The following is a description of a gene set: species: Homo sapiens Genes predicted to be targets of miRBase v22 microRNA hsa-miR-194-5p in miRDB v6.0 with MirTarget v4 prediction scores > 80 (high confidence targets). Human Gene Set: MIR194_5P from publication Chen Y, Wang X (PMID 31504780), and this is the list of marker genes: BRMS1L, SOX5, KDM5A, RHEB, MID1IP1, CPED1, BTBD7, BCKDHA, DACH1, TCEAL4, CASK, ITPKB, SPRED1, XPNPEP3, WDR37, STEAP2, ZFHX3, TSPAN7, PELO, NMB, NRN1, CLCN5, RPL17-C18orf32, NEMP1, SLK (STE20 like kinase), ACVR2B, ATP2C1, HBEGF, ACBD3, CHORDC1, CHD1, RAI1, CNR1, NIPSNAP3B, CUL4B, YTHDF1, RNF125, QKI, MRS2, KIAA1210, MTMR6, LYN, LPXN, RAB38, LINC02902, TRIM23, IVNS1ABP, HHLA2, MGAT4A, SLC12A6, OR51E2, KRT25, CLEC2A, ARK2N, MINDY2, REV3L, TAOK1, ZNF532, CADM1, GORAB, TTC7B, DYRK1A, ZNF615, CNPY1, SNAP91, MEP1A, HOOK3, SLC25A27, KHDRBS2, ARHGAP21, SLC30A1, TMEM108 (transmembrane protein 108), PAIP2, RSBN1L, CAPS2, PDHB, C21orf91 (NCBI Gene Id 89755), FGA, MTSS1, IGF1R, NWD2, LSAMP, FAM169A, ATP6V1H, PTPN12, GOT2 (NCBI Gene Id 2806), RNGTT, LCOR, PRICKLE2, CDK14, WWP1, TAF4, LURAP1L, SFRP2, GPATCH2L, MAP2, FOXE1, DSTYK (NCBI Gene Id 353293), EMCN, STAU2, CHD4, KCTD17, EPC2, SLC12A2 (solute carrier family 12 member 2), GRHL2, SETD5, SEC24B, ONECUT2, ANGPTL1, NUDC, EPHA5, PITPNM2, USP6NL, HNF1B, ACHE, TSPAN1, SDC4, EVC2, BNIP2, FBXW7, NFAT5, SAMD4A, NTNG1, ITSN1, PHLDA1, FZD6, CTDSPL2, LIN52, GPATCH2, USP44, PPFIBP1, BICD2, OSBPL11, SFXN3, TMED5, SGCE, OTULIN, FLI1, HECTD2, RUFY2, SATB1, JADE1, KMT2C, SLC7A5, NAA50 (N-alpha-acetyltransferase 50, NatE catalytic subunit), RXRA, LIN7C, SLC1A3, SUMO2, ZFHX4, LRRFIP1, LRCH2, LAMP2, NACA, PPP3CA, SMKR1, KLF12, ERGIC2, SEPHS1 (selenophosphate synthetase 1), PHLPP1, WAPL, DISC1, ERG, OSTM1, SLC28A1, ABCB10, SPTY2D1, YAP1, GYG1, PARVA, ARID2, LINGO2, LUC7L3, SLC10A7, RSF1, HSPA4L, RNF217, CEP170, RAB3B, U2SURP, CHD6, PTPN20, PTPN2, MIDEAS, TENT5A, PPTC7, RAP1B, SSH2, PJA2, OSBPL8, ZFAND5, CXCL3, TBRG1, NUF2 (NUF2 component of NDC80 kinetochore complex), ZNF516, C18orf32, KMT5A